Given this list of marker genes EPHB2, FOSL2, CRYBG1, FHL2, PSG9, GADD45A, PDP1, MAP1B, LOXL2, FBLIM1, ACTN4, EMP3, LMNA, CDKN1A, THY1, CTSB, SMARCA4, MMP1, PERP, SPOCD1, TPM1, ADGRG1, KRT15, PTPN7, FLNB (filamin B), MT1H, ITGA3, DCBLD2, CCL2, ARL4C, SMARCA2 (NCBI Gene Id 95083), MIR503HG, HKDC1, TEC, LGALS1 (NCBI Gene Id 3956), MFGE8 (milk fat globule EGF and factor V/VIII domain containing), ABHD2, SERPINE2, MT1L, ATP2B4, AGT, PSG4, FADS3, AHNAK, ITGA5, S100A2, COTL1, UBE2H, PLXNB2, IGFBP4 (NCBI Gene Id 3487), PHLDB1, JUN, CTSH, PSG5, here is a description of the gene set: species: Homo sapiens from publication Hendricks KB, Shanahan F, Lees E (PMID 14673169) Human Gene Set: HENDRICKS_SMARCA4_TARGETS_UP Human BRG1, a subunit of the Swi/Snf chromatin remodeling apparatus, has been implicated in regulation of cellular proliferation and is a candidate tumor suppressor. Reintroduction of BRG1 into a breast tumor cell line, ALAB, carrying a defined mutation in the BRG1 gene, induced growth arrest. Gene expression data revealed that the arrest may in part be accounted for by down-regulation of select E2F target genes such as cyclin E, but more dramatically, by up-regulation of mRNAs for the cyclin-dependent kinase inhibitors p21 and p15. Protein levels of both p15 and p21 were induced, and p21 protein was recruited to a complex with cyclin-dependent kinase, CDK2, to inhibit its activity. BRG1 can associate with the p21 promoter in a p53-independent manner, suggesting that the induction of p21 by BRG1 may be direct. Further, using microarray and real-time PCR analysis we identified several novel BRG1-regulated genes. Our work provides further evidence for a role for BRG1 in the regulation of several genes involved in key steps in tumorigenesis and has revealed a potential mechanism for BRG1-induced growth arrest. Genes up-regulated in ALAB cells (breast cancer) upon reintroduction of SMARCA4 expressed off adenoviral vector.